The following is a description of a gene set: electronically inferred by orthology from the curated human pathway part of: Phase I - Functionalization of compounds studied in species Mus musculus This event has been computationally inferred from an event that has been demonstrated in another species.<p>The inference is based on the homology mapping from PANTHER. Briefly, reactions for which all involved PhysicalEntities (in input, output and catalyst) have a mapped orthologue/paralogue (for complexes at least 75% of components must have a mapping) are inferred to the other species. Reactome Pathway: FMO oxidises nucleophiles, and this is the list of marker genes: Fmo1